The following is a description of a gene set: Establishment of the barrier between the blood and the brain. The cells in the brain are packed tightly together preventing the passage of most molecules from the blood into the brain. Only lipid soluble molecules or those that are actively transported can pass through the blood-brain barrier. Mouse Gene Set: GOBP_ESTABLISHMENT_OF_BLOOD_BRAIN_BARRIER species: Mus musculus, and this is the list of marker genes: Ndp, Lrp6, Foxp3 (NCBI Gene Id 20371), Abcb1a, Dmd, Fzd4, Lrp5, Vps4b, Ctnnb1 (catenin beta 1), Cldn3, Mxra8, Bpgm, Reck, Wnt7a, Abcb1b, Mfsd2a, Lsr, Ttpa, Adgra2, Trpv1